The following is a description of a gene set: studied in species Homo sapiens from publication Lindgren D, Liedberg F, Andersson A, Chebil G, Gudjonsson S, Borg A, Månsson W, Fioretos T, Höglund M (PMID 16532037) We used gene expression profiling, mutation analyses of FGFR3 and TP53, and LOH analyses of chromosome 9 and the TP53 region on chromosome arm 17p, to molecularly characterize 75 Ta and T1 bladder carcinomas. We identified four major cellular processes related to cell cycle, protein synthesis, immune response, and extra cellular components that contribute to the expressional heterogeneity of early-stage urothelial cell carcinoma (UCC). Activating FGFR3 mutations were found at the highest frequency in G1 tumors (80%), and showed a strong correlation with FGFR3 expression. In contrast, G3 tumors displayed mutations in less than 10% of the cases and a low level of FGFR3 expression. Even though LOH on chromosome 9 was not associated with any specific expression pattern, our data indicate that loss of chromosome 9 is associated with tumor development rather than initiation. The combined analyses suggest the existence of two types of UCC tumors, one which is characterized by FGFR3 mutation or expression, high expression of protein synthesis genes, and low expression of cell cycle genes. Furthermore, the presented data underscore FGFR3 receptor involvement in urothelial cell transformation as the presence of FGFR3 mutations has a major impact on the global gene expression profile of bladder carcinomas. Human Gene Set: LINDGREN_BLADDER_CANCER_CLUSTER_1_DN Down-regulated genes whose expression profile is specific to Custer I of urothelial cell carcinoma (UCC) tumors., and this is the list of marker genes: BIRC3, H2AZ1, NEU1, BCAT2, OR4F16, TJP3, SLC17A5 (NCBI Gene Id 6479), ICAM3, AKR7A2, CDK1, ACTN1, IL32, HILPDA, HSPD1, TNK2, SLC46A1 (NCBI Gene Id 113235), LAMA4, UCK2, SLFN11, TOMM34, NR4A1, SMARCA4, MAP3K14, PLAC8, NUPR1, RAB17, TMPO, NAV2 (neuron navigator 2, NCBI Gene Id 89797), IL2RA, GTSE1, SLC12A2, CCN1, CIT, COL4A2, ATG9B, VPS37C, STAG2, CENPE, DEDD, SFMBT1, HCLS1, PRRC1, HSD3B7, GRK5, ERBB3, BLTP3B, NES, CAPG, ZNF148, ITSN2, DAG1, ANXA6, RRP1, FERMT3, DLGAP4, MYLK, BPGM, PRSS8, APIP, GCN1, ZWINT, FABP3, GEM, MGAT1, DEPDC1, UBE2C, CCNB1, TMEM108, LGALS2, TK1 (NCBI Gene Id 7083), CENPU, MCM8, POLE, PEA15, PPP1R14C, CDCA4, AURKA, CES2, TNC, PDIA5, MAL, PDE1A, SEC24A, MELK, MAP1A, HTRA3, PLK4, ABCF2, MT1G, CDC25B, RGS16 (regulator of G protein signaling 16), ZDHHC18, CREB3L2, H1-0, IL2RG, NCAPG2, ARHGAP15, DAB2, RPS27L (NCBI Gene Id 51065, ribosomal protein S27 like), CCNE1, TCF25, GSTM2, ST8SIA3, SLC43A3, CKS1B (CDC28 protein kinase regulatory subunit 1B), STAT5B, PRC1, NEDD9, CDCP2, THBD, MNX1, GFOD1, SGO2, KIFC1, ACSF2, RAD54L, GNB3, NID2, ARRB2, SLC36A4, PDXDC1, FAM50A, NCKIPSD, MCAM, P4HB, FYN, COL18A1, CCL16, WDHD1, ACOT7, NEURL1B, HMGCS1, RCBTB1, GINS2, MAGEA11, EXO1, RBL1, TIMP2, CLIC4 (chloride intracellular channel 4), KPNA2, KIF4A, DLGAP5, PEPD, MGP, KIF21B, SLC44A2, KIF11 (kinesin family member 11), AKAP12, ZNF703, SMURF1, MYO5BP2, CTPS1, TAGLN2, SEC13, PRUNE1, ATAD2, MAN1C1, SAE1, TRIP13, TMEM97, PMM1, NFKB2, JPT1, FBLN2, WFDC21P, PREX1, RAD51, PMP22, TMEM125, RAI14, ENO2, CD80, COX17, E2F1, MINK1, COL5A2, PHF19, SELL, ACOX3, MOCS1, DBI, CENPA, PDXP, CDCA7, NECTIN2, CENPN, PAPPA, PVALB, CCL13, MYBL2, SPATA13, KRT23, EBF1, RCC1L, PAFAH1B3, NHERF1, MNS1, TUBA1A (NCBI Gene Id 95407), ADAM19, KDELR2, MOBP, TTC39A, LOXL2, CDCA2, APEX2, SUN2, BUB1, AMPD2, DCLK2, HIP1, NFE2, PTTG1, SSR1, IER2, NTRK2, GSTM4, ILF3, GPX3, HEYL, TNFRSF11A, PCSK6, TEAD2, APLNR, ACSL1, PELI1, SNX5, NSD2, CCNB2, ARHGAP30, KLF9, MCM5, IDO1, LGALS1, PITX2, ERBB2, VDAC1, ZNF286A, CDT1 (NCBI Gene Id 81620), CTSA, RFC3, CASP6, INSIG1, ADAM15, TRIM11, CLDN4, SLC26A6, CLN3, PLCXD1, SH3KBP1, CDKN2C, PATL1, CDC6, ITGB7, RELL1, CDC45, COL15A1, AMOTL2, C1orf216, IDH2, TFRC, RGL1, PRRX1 (paired related homeobox 1), BIRC5, EPHX1, SUSD6, CXCL1, PPP1R12B, DNM1, GNL3L (NCBI Gene Id 54552), PYCR1, NUDT1, RFC4 (replication factor C subunit 4), YPEL3, SLC1A3, LCOR, TCF19, NUP62 (nucleoporin 62), RBM28, CELSR3, PDGFRB, CACUL1, MTHFD2, B4GALNT3, TOP2A, APOBEC3B, STMN1, BLVRB, RASSF2, MCM6, KLHL6, CTNNBL1, PSMA1, EFNA1, C2CD2L, PLK1, DQX1, CCSAP, RASSF5, GPA33, HMOX1, ASAP1, FLVCR2, NEK2, ORC1, HMGB2, CDC25A, SYNGR2, CERS2, RRM2 (NCBI Gene Id 6241), FILIP1L, SPCS1, MYL9, CENPF, TRAIP, EBP, RUBCN, KIF23, ALDH8A1, MOB2, PSMB4, ENAH, PIK3AP1, PIK3C2B, CHDH, CDCA8, CAMK1, PSMD11, MPHOSPH9, ALAS1, PDGFRL, ST3GAL2, BID, TEX30, PRG2, RHBG, CGN, TACC3, PALM2AKAP2, PHF2, CAMK2G, TNFAIP1, RNASEH2A, KIF2C, EMP2, POC1A, RACGAP1, FAM83D, EZH2, CEBPA, CDK9, SH2D2A (SH2 domain containing 2A), BRCA1, SBNO2, SQLE, CISH, PMS2P4, KIF14, AP1B1, POP7, CHAF1B, PSRC1, SRGAP2, RGS10, HDGF, NRP2, S100A4, VASN, NDRG2, IL17RB (NCBI Gene Id 55540), ABI3BP, DYRK2, CDC7, XBP1, CA2, MACROH2A1, DAAM2, SH3BP5, PMM2